The following is a description of a gene set: Binds to and increases the activity of a GTPase, an enzyme that catalyzes the hydrolysis of GTP. species: Homo sapiens Human Gene Set: GOMF_GTPASE_ACTIVATOR_ACTIVITY, and this is the list of marker genes: ARRB1, SGSM3, THY1, ARHGAP23, STXBP5, ARHGEF16, ARHGAP29, TBC1D3G, TBC1D21, ARHGDIG, ERRFI1, ARHGAP5, ARHGAP6, RGS10, TBC1D10C, IQGAP3, RGS8, RGS9, ASAP1, TBC1D7, RP2, RGS6, ARFGAP3, RASA3, RIN2, ARHGAP40, RGPD4, ARHGEF1 (Rho guanine nucleotide exchange factor 1), RANBP2, PDGFRB, AGFG1, SYDE2, GNB5, ARHGAP21, ARHGEF10L, FLCN, USP6NL, RAB3GAP2, EVI5L, ANKRD27, ARHGAP8 (Rho GTPase activating protein 8), TBCD, TBC1D22B, ARHGEF6, SYDE1, PREX1, ARHGAP25, ARHGAP44, RGS18, ARHGAP19, AGAP2, AGAP5, CHML, TBC1D8, BCR, RGPD5, ARHGDIA, BNIP2, TBC1D4, RASA1, DEPDC1B, RAB3GAP1, ARHGAP22, RANBP1, AGAP11, AGFG2, SIPA1, SRGAP2, IQGAP2, MTSS2, RGS4, ARHGAP11A, PREX2, ASAP2, ARHGAP30, STARD13, TSC2 (TSC complex subunit 2), PLCB1, RAP1GAP, ABR, WDR41, PLEKHG6, RGS12 (regulator of G protein signaling 12), CDC42EP2, RGS5, ARFGAP1, SEC23B, GIT2, SYNGAP1, TBC1D3H, TBC1D19, ARHGAP15, RGPD6, SMCR8, TBC1D20, TBC1D10B, DEPDC1, ARHGAP32, OCRL, ADAP2 (ArfGAP with dual PH domains 2), HTR2B, DAB2IP (DAB2 interacting protein), SEC23A, GAPVD1, RALGAPB, ELMOD2, DOCK7, ALS2, DOCK2, TBC1D30, TBC1D3F, TBC1D3I, FAM13B, GARNL3, ELMOD1, JUN, RASGRP3, ARAP3, TBC1D17, SMAP1, ARHGAP18, LLGL1, NCKAP1L, TAGAP, TBC1D5, GDI1, NF1, ELMOD3, RALGAPA2, TBC1D3E, RASAL2, TBC1D12, DEPDC5, ARHGDIB, TBC1D3D, LRRK2, RABGAP1L, TBC1D24, SRGAP3, TBC1D13, OPHN1 (oligophrenin 1), SIPA1L2, TBC1D3C, ARFGEF1, FAM13A, TBC1D14, TBC1D9B, ARHGAP1, TBC1D3, TBC1D3K, ARFGAP2, C9orf72, DEPTOR, ARAP2, CHN1, TBC1D15 (NCBI Gene Id 64786), RIN3, SOS1, RGS1, ARHGEF11, GIT1 (NCBI Gene Id 28964), TBCK, DNM1L, RAPGEF2, ARHGAP33, DOCK3, NPRL2, ARHGAP35, RGPD8, LLGL2, IQGAP1, ASAP3, RASA2, AGAP9, RALGAPA1, TBC1D8B, HACD3, NPRL3, RGS3, ARHGAP26, RGS16, VPS9D1, SMAP2, SIPA1L3 (NCBI Gene Id 23094), RACGAP1, TBC1D9, ARHGAP45, LARS1, RGS7, RGPD3, TBC1D1, ARHGEF15, RANGAP1, TBC1D10A, SIPA1L1, TBC1D26, TBC1D2, EIF5 (NCBI Gene Id 1983), MYO9B, ACAP3, ARHGAP39, TBC1D3L, AGAP6, PLXNB1, AGAP1, GMIP, AGAP4, RGPD2, ARHGAP24, TBC1D16, RASAL1, SRGAP1, GDI2, CHM, RAP1GAP2, ACAP2, TBC1D25, MYO9A, STARD8, RGS2, ARHGAP4, RIN1, ARHGAP20, RALBP1, DOCK4, ALS2CL, DLC1, RGS17, AGAP3, ACAP1, SGSM2, RGPD1, TIAM2, ARHGAP42, RGS11, NRP1, ARHGAP9, TBC1D3B, ARHGAP28, DOCK1, ARHGAP27, ECT2, TBC1D2B, GRTP1, DOCK5, RGS20, ARHGAP36, RINL, STXBP5L, SGSM1, ARHGAP17, ADAP1, AGAP7P, ARHGAP12, RABEP2, ARHGEF12 (NCBI Gene Id 55406), ARHGAP11B, SH3BP1, ALDH1A1, RABEP1, EVI5, ADGRB3, GNAQ, VAV3, RGS14, ARHGEF19, ARHGAP31, RASA4B (NCBI Gene Id 100271927), CHN2, RASAL3, RASA4, ARAP1, RABGAP1, ARHGAP10, TBC1D22A